Given this list of marker genes Aqp1, Pkp1, Slc5a1, Cftr, Aqp8, here is a description of the gene set: Mouse Gene Set: GOBP_TRANSEPITHELIAL_WATER_TRANSPORT The directed movement of water (H2O) from one side of an epithelium to the other. studied in species Mus musculus